Given this list of marker genes MAPT, SNTA1, MAPK13, EEF2K, MAP3K20, STMN1, MAPK12, CCND1, MAP2K3, MAP2K6, PKN1, here is a description of the gene set: Signaling mediated by p38-gamma and p38-delta studied in species Homo sapiens Human Gene Set: PID_P38_GAMMA_DELTA_PATHWAY from publication Schaefer CF, Anthony K, Krupa S, Buchoff J, Day M, Hannay T, Buetow KH (PMID 18832364)